The following is a description of a gene set: studied in species Homo sapiens Glucocorticoid receptor pathway Human Gene Set: WP_GLUCOCORTICOID_RECEPTOR_PATHWAY, and this is the list of marker genes: SEC14L1, POU5F1, CDC42EP3, NFKB2, CUL1, MFGE8, ADGRF4, HSP90AA1, NR1I3, CCL20, CCL2, DNAJC15, CPEB4, B3GNT5, ENC1, JUN, BHLHE40, ALOX5AP, SPRY1, SLC26A2, PTGS2, SPINK13, TGFBR3, RXRA, SLC19A2, ABHD2, ANGPTL4, PTGES3, DNER, NR3C1, BIRC2, SERPINB9 (serpin family B member 9), ZIC2, STOM, GPR153, ARL5B, TNS4, PDE4B, CAVIN2, FGFBP1, SNAI2, NAV3, ANKRD1, PLK2, MGAM, BIRC3, RGS2, FGD4, ACKR3, GADD45B, PRRG4 (NCBI Gene Id 79056), AMIGO2, PPP1R14C, AKAP13, THBD, KTN1, S100P (NCBI Gene Id 6286), TSC22D3, PMP2, SRGN, SCNN1A, TNFAIP3, LRRC8A, EDN2, EPB41L4B, CDKN1C, SERTAD2 (NCBI Gene Id 9792), NR1I2, ETNK2, IL11